Given this list of marker genes ABR (ABR activator of RhoGEF and GTPase), DPY19L4, DAP, MCM4, ACOT11, ANLN, BICD2, CLN8, LSR (NCBI Gene Id 54595), RAB5IF, FAM89B, TSSC4, HK3 (hexokinase 3), VPS35, ANXA7, TRIT1, ZNF496, ANXA3, SURF4, STARD3NL, COPA, ATG9A, FGD1, GNAQ, LMF2, ACACA, KPNA3, EID1, CA9, MEGF8 (multiple EGF like domains 8), FGFBP3, ALMS1 (ALMS1 centrosome and basal body associated protein), TBRG1, PALB2, IDE, RTN4, FGD6, PLAAT3, EIF4A1, UCP2, JPT2, RAB7A, SNX1, STX12, XKR5, ENTPD6, PLEKHG5, RCC1, FUCA1, PDCD6IP, SIPA1L3, RCN2, SLC33A1, RASA4, PACS2, ATP6AP2, HLA-DQA1, CERS6, ENPP4, TUBA1B, PADI2, IMPA2, ELAC2, ADAM19, FOXN2, SCAMP1, CTNND1, FXYD5, SH3BP4, SYNE1, CD36, SERPINB9, SLC22A5, EEF1B2, EPB41L2, IFNAR2, NLRP3, SANBR, TUBB, PALLD (palladin, cytoskeletal associated protein), NDST2, MRPL42, VRK2, MAP2K4, PTMS, PIP4K2A, C11orf54, NHLRC2, EPSTI1, DPP4, INPP5B, DYM, SYNRG, PYGO2, GPAA1, PKIB (cAMP-dependent protein kinase inhibitor beta), PLEKHB2, VDAC2, KRT80, PAK2, PCDH20, UNC119, DERL2, COP1, TTC8, CHEK2, LRRC40, CASP7 (caspase 7), HEXA, SH3BP5L, SLAMF7, ARHGEF39, IQGAP3, DPYSL2, LARS1, ESPL1, IL13RA1, STAT5A, TMTC3, STARD8, HCLS1, ZBTB8A, MATK, FAM168A, ENTPD1, NDC1, PDIA3, ATP5IF1, PLPP2, VKORC1L1, ERI1 (NCBI Gene Id 90459), MFSD14B, IL3RA (NCBI Gene Id 8281), MBOAT1, KCTD21, GNB2, RCBTB2, SELENOI, PDE1B, CD86, PARVG, GARS1, TOX4, LTBR, ZFAND4, SLC25A38, MAGT1, SUMO3, EEFSEC, CRTAP (NCBI Gene Id 253263), TIFA, CKAP2L (cytoskeleton associated protein 2 like), AURKA, MYO18A, SPAG5, UQCRB, SEPHS1, TM2D2, B4GALT4, CLINT1, BRIP1, ZDHHC23, SLK, FAM219A, GMPR2, S100A6, PSEN1, VAMP3, CD80, EIF2B2, KHK, MSH2, WDR41, NOSTRIN, TUSC1, CEP83, CRIP1, ITPK1, TOPBP1, SGO1, FLOT1, PLIN5, PSMB9, MOGS, HSPB6, TMCC2, KIFAP3, HDAC6, IPCEF1, PSMA8, CFAP410, PIMREG, PEA15, NDRG1, UXS1, DKK3, DGLUCY (NCBI Gene Id 80017), GLCE, SUMF1, CTDP1, here is a description of the gene set: Genes up-regulated in B lymphocytes: memory versus transitional CR2 low. Goals/objectives: to identify various gene expression in B cell subsets derived from human PBMC and cord blood from publication Suryani S, Fulcher DA, Santner-Nanan B, Nanan R, Wong M, Shaw PJ, Gibson J, Williams A, Tangye SG (PMID 19965666) Human Gene Set: GSE17186_MEMORY_VS_CD21LOW_TRANSITIONAL_BCELL_UP studied in species Homo sapiens